The following is a description of a gene set: Human Gene Set: MORF_MDM2 species: Homo sapiens Neighborhood of MDM2 Neighborhood of MDM2 Mdm2, transformed 3T3 cell double minute 2, p53 binding protein (mouse) in the MORF expression compendium, and this is the list of marker genes: CADM4, PART1, MYT1, FGF18, ATP6V0A2, IPO9, FGF2, CLOCK, CRHR1, PAXIP1, HTR1E, PHLDB1, CCR3, ZNF200, BCL2L11, SPA17, STAG1, IL7, MDM2, ELAVL2, DNAJC16, MLLT10, TNFRSF25, ZBTB14, R3HCC1L, CMKLR2, ZNF157, RPS6KA5, CACNA2D1, GLE1, PTPRB, TBX5, MAGI1, ARFGEF2, HOXD4, HCRTR2, SIX6, IL11RA, WBP4, CLCN3, ABO, ATP2B2, SOAT2, DPT, CD3E, FNTB, IFNA1, FAS, BRCA1, KLRC4 (killer cell lectin like receptor C4), TNK1, ATF6B, POU6F1, CXCL5, CDC73, FLT1, NPAS2 (NCBI Gene Id 84195), CEP162, CYP2E1, GJB5, GRIK1, PRPS1L1, SLC4A3, IL16, SLC46A3, DRD1, SLC17A1, TACC2, GABRB2, NTNG2, DMPK, NFAT5, GCM1, TSPAN2, FBXL4, SRPK3, NXPE3, PSD, ERCC4, NCKIPSD, HSD3B2, KRT34, CTRL, IL5, PRELID3A, SLC2A1, ZNF141, ERC2-IT1, F2RL1, TBXT, POLR3F, FSHR, DGCR5, TANC2, POLR1HASP, H3C6, COL14A1, GMPR, BARX2, ADAM20, NR1I2, MAGEA9, OR2B6, JADE3, BNIP1, KRT86, COX6A2, KRT33B, GRIK5, ABCB1, TFDP2, GPR18, SLC33A1, MPZL2, ABCB9, ABCC8, NHEJ1, NEB, ITIH3, PLA2R1, STAC, TSSK2, GUCY2F, GPLD1, KRT33A, GPR19, CAMK4, JRKL, GNG4, ZNF132, BRINP3, MSL3, FOSL1, ATF2, SLC4A8, MFN1, ZNF134, BMP10, ST8SIA1, ADCY3, ADCYAP1, UBE4B, KRR1, DRC3, CYP4F2, FZD5, RYR3, MAP2K6, RB1CC1 (NCBI Gene Id 9821), GPR15, RNF24, POU6F2, NR3C2, PTPRS, RBBP7 (RB binding protein 7, chromatin remodeling factor), TBX19, ROR2 (receptor tyrosine kinase like orphan receptor 2), CTSB, DNAJC22, TMEM26, KRT1, ITGBL1, AKAP3, ABCB10, HOXC11, ATP4B, MPZL1, COL8A1, ATP8B1, AOC4P, ULK2, CYP11A1, MYH2, PHOX2B, LILRA1, SLC17A3, S100A5, VKORC1, MSH3, SLC6A2, MAP2K7, RORB, ZNF202, KCNA5, NPFF, COLGALT2 (NCBI Gene Id 23127), LILRA4, PDE6A, POLR2K, CDR1, TRIO, ZSCAN26, DBT, P2RY10, PLPPR4, PRKCA, ZBTB40, IVL, CCL16, ARL3, HNF1A, C1orf216, GCA, SUPT3H, NOVA1, PAX6, IGKV7-3, RREB1 (ras responsive element binding protein 1), LECT2, PCM1, CASP10, PPP1R12B, ELOVL6, LGI1 (leucine rich glioma inactivated 1), PAX7, BRD4 (NCBI Gene Id 90616), SIM2, PSG1, MON2, ATP10B, MC5R, ZNF266, RBMXL1, CFH, PLEKHB1, SLC22A6, APOBEC1, AMMECR1, EDIL3, ADAMTSL3, PAX9 (NCBI Gene Id 5083), CDKL5, GPR171, MAGEA8, SLC15A1, COL19A1, CSRP3, IFNW1, ECM2, GUCY2C, TRIM24, PDE10A, PGM3, CALN1, IL4, CPEB3, RAD51D, CNTN6, PTPRR, TENM4, MINDY2, PVR, NOS2, ERC1, COQ7, MYOZ3, SERPINA4, TTTY1, PHF10, IFNA14, AQP7, CPB2, KNG1, PPP2R5B, SULT4A1, SYT5, MAP2, EPHB2, GLRA3, EXOC4, SLC16A5, PPP1R1A, ATXN3, RXRG, KRT2, RBMS3, DMD, LPGAT1, RSC1A1